Given this list of marker genes GNAT1, ADAMTS20, BCL2, EDN3, VPS33A, BLOC1S5, SPNS2, HPS4, BAX, KITLG, ADAMTS9, ZEB2, IHH (Indian hedgehog signaling molecule), TPCN2, BCL2L11, BLOC1S6, GNAT2, here is a description of the gene set: Human Gene Set: GOBP_REGULATION_OF_PIGMENTATION species: Homo sapiens Any process that modulates the frequency, rate or extent of the deposition or modulates the distribution of coloring matter in an organism.